The following is a description of a gene set: Mouse Gene Set: GOBP_G2_MI_TRANSITION_OF_MEIOTIC_CELL_CYCLE The cell cycle process in which a cell progresses from meiotic G2 phase to M phase of meiosis I. studied in species Mus musculus, and this is the list of marker genes: Cdc25b, Ccnb2, Pdik1l, Cdc25c, Usp17le, Cdc25a, Pkmyt1, Stk35, Ndc80